The following is a description of a gene set: studied in species Homo sapiens Reactome Pathway: Recognition and association of DNA glycosylase with site containing an affected pyrimidine Base excision repair is initiated by a DNA glycosylase which first recognizes and removes a damaged or incorrect (e.g. mismatched) base. part of: Depyrimidination, and this is the list of marker genes: TINF2, H2BC26, H2BC13, H2AC6, H2AC20, H2BC9, H2BC15, NEIL2, H2AC7, H2BC4, TDG, ACD, H4C1, H2AX, POT1, H2BC1, H2AB1, H2AZ2, H2BC14, H3-4, TERF2, H2AC4, NEIL3, UNG, SMUG1, H2BC21, H2BC17, TERF1, H2AJ, OGG1, MBD4, NEIL1, H2AC18, H2BC3, H2BC12, H2BC12L, H2AC14, H2BC11, NTHL1, TERF2IP, H2BC5